The following is a description of a gene set: studied in species Homo sapiens The process in which relatively unspecialized cells of the ectoplacental cone acquire specialized structural and/or functional features that characterize chorionic trophoblasts. These cells will migrate towards the spongiotrophoblast layer and give rise to syncytiotrophoblasts of the labyrinthine layer. Human Gene Set: GOBP_CHORIONIC_TROPHOBLAST_CELL_DIFFERENTIATION, and this is the list of marker genes: E2F8, MAP3K4, E2F7, FZD5, DNMT3L, ASCL2, HTRA1